Given this list of marker genes Mex3c (mex3 RNA binding family member C), Cxcr5, Pygo1, Usp30, Pwwp2a, Itgb3bp, Iqce, Pacsin2, Ube2v1, Mchr1, Mtmr6, Traf3, Lgals1, D430041D05Rik (RIKEN cDNA D430041D05 gene), Jazf1, Pemt, Tnpo1, Cpe, Larp1 (NCBI Gene Id 73158), Fer, Slc10a2, Zfp207, Ids, Shisa6, Met, Zfp24, Tceanc2, Wdr33 (NCBI Gene Id 74320), Lypd6, Efl1, Cdkn2aip, Kcnk10, Plxdc2, Cep128, Zfp516, AI593442, Samd5, Slc25a51, Enoph1, Nif3l1, Synj2, Rasl11a, Inpp4b, Dsc1, Nog, Pik3ca, Aldh1a7, Siah1a, Lpar1 (lysophosphatidic acid receptor 1), Phf20l1, Prickle3, Chchd3, Nipbl, Spast, Mecp2, Clmp (CXADR-like membrane protein), Atp2c1, Dzip1l, Fxr1, Tmem258, Sez6l, Myo5a (myosin VA), Tktl1, Armc1, Gdpd4, Ccdc62, Dlgap1, Jade1, Ap1g2, Npr3, Map2k4, Ino80d, Ankrd28, Lrtm2, Star, Xpo1 (NCBI Gene Id 103573), Fam114a1, Rnf152, Slc37a2, Mbd3l2, Tstd2, B4galnt2, Srp68, Garem1, Fam98a, Ovca2, Bcor, Phactr2, Cox11, Rbm39, Gls, Appl1, Abhd3, Nufip2, Cdh4, Lrrc59, Triobp, Arx, Eya2, Mfap5, Steap2, Cbx3 (chromobox 3), Metap2, Iars2, Zfp267, Baz1a, Usp7, Actr3, Cntn4, Lingo2, Tenm3, Naf1, Phox2b, Gpm6b, Tmem135, Tspan15 (NCBI Gene Id 70423), Wipf1, Hcn1, Alx1, Slc1a5, Nr2f2, Pkd2l2, Ephb3, Ptpn4, Calcr, Acot4, Tra2b, Prdx1, Uncx, Megf11, Kctd4, Tmed6, Esr1, Trip13, Tpm2, Plcl2 (NCBI Gene Id 29868), Spata18, Rai2, Vps50, Pdik1l, Tex13c1, Fgf10, Atrn, Fbxo32, Map1lc3b, T, Ap3s1, Grid1, Chst2, Sox2, Cxadr, Clcn4, Tlnrd1, Tead1, Nxpe2, Antxr2, Dpp8, Uri1, Ube4b, Avl9, Bahcc1, Capn3 (NCBI Gene Id 98918), Stxbp5l, here is a description of the gene set: from publication Chen Y, Wang X (PMID 31504780) Genes predicted to be targets of miRBase v22 microRNA mmu_miR_511_5p in miRDB v6.0 with MirTarget v4 prediction scores > 80 (high confidence targets). studied in species Mus musculus Mouse Gene Set: MIR_511_5P